The following is a description of a gene set: from publication Busslinger GA, Weusten BLA, Bogte A, Begthel H, Brosens LAA, Clevers H (PMID 33691112) species: Homo sapiens Human Gene Set: BUSSLINGER_DUODENAL_STEM_CELLS, and this is the list of marker genes: IRF2BP2, ELAPOR1, EIF3A, SERBP1, PAPOLA, TM4SF1, ATF3, CPS1, IPO7, TMEM230, IER2, RPL37A (ribosomal protein L37a), RPL27A, YWHAE, ITGA6, PIK3R1 (NCBI Gene Id 5295), CCL25, BTF3, CLDN3, ZFAS1, CEMIP2, ADRA2A, HNRNPDL, HSPD1, SPINK1, SOX4, SRSF6, ARF4, SELENOW (selenoprotein W), SOX9, CD46, MARCKSL1, RPL10, CEL, HMGB1, UBXN4, TRIM24, REG1A, AQP1, SNHG8, RPS23, TOMM7, IER3, CRLS1, CHCHD2, RPS15, RHOBTB3, RPS13, NCL, RPS18, BANF1, EEF1G, SNHG6, HNRNPC, EEF1A1, PKDCC, ARID5B, SNRPE, EIF3E, HSPA8, NSA2, APP, EML4, EEF2, ACTN1, HNRNPU, CNBP, COX7C, RPL8, GSTP1, CFTR, HNRNPA2B1, RCC2, LRIG1, TM9SF3, GOLM1, NOP56, NFIB, ERGIC3, RPL4, SCARNA9, ONECUT2, PDLIM1, RPL6, RPS7, PPIA, BMP4 (bone morphogenetic protein 4), TTC3, ATP5MC2, RPL15, GNL3, RPS29, CCND2, RPL27, NUCKS1, GAS5, BTG2, CD44, TXN, AHCY, RPS20, CES1, HNRNPK, ESRP1, RPL35, RPL41, HMGN1, RPS14, MECOM, SNHG29, RPL11, YWHAQ, BCL11A, CANX, RPL35A, RPS5, LRPPRC, FBL, CA9 (NCBI Gene Id 768), RPL39, RPL13A, ADD3, RPL31 (NCBI Gene Id 6160), RPL3 (ribosomal protein L3), RPS28, RPS2, EPCAM, RPL23, RNF43, PTGES3, CDCA7, XIST, RPL18, RACK1, MT1G, RPS15A, TOP2B, NONO, IMPDH2, VDR, ENC1, ZFP36L2, TXNIP, REPIN1, SYNCRIP, CD9, SPINT2 (NCBI Gene Id 10653), DSTN, ADH1C (NCBI Gene Id 126), NFIA, RPS16, HNRNPD, RPS27, SRP9, SH3D19, CLU (clusterin), CCND1, MLXIP, MLEC, U2AF1, HNRNPA1, EIF4B, SESN1, SH3BP4, RPL36, ASCL2, RPS27A, ZFP36L1, RPS4X, ZNF503, EIF2S3, FCGRT, RPS25, RPS11, RPL32, JUN, NR4A1, EIF3L, SNRPB, DMBT1, SH3BGRL2, GPX2 (NCBI Gene Id 2877), KRT8, RPL37, CDC42EP5, RPL30, EPHB2, HES1, C9orf152, MYB, DUT, HDAC2, SLC12A2, RPL34, FERMT1, FAM120A, SMOC2, PABPC1, TPD52, ATRX, RPL22L1, RCN1, RPL24, RPS3A, TKT, SNHG5, EIF4G2, AGR2, RPL22 (NCBI Gene Id 65281), HBEGF, CCT6A (chaperonin containing TCP1 subunit 6A), BCLAF1, SNX5, RPL5, SLC38A2, KHDRBS1, EGR1, RPS24, CERS6, RPS12, BEX3, RPL38, SMARCC1, HMGA1, NRARP, CDKN1B, EIF1AX, APEX1, DDAH1, ETS2 (ETS proto-oncogene 2, transcription factor), RPL7A, PTMA, REG3A, EDN1, CHDH, MATR3, CBX3, CDK6, LYZ, OLFM4 (NCBI Gene Id 10562), DACH1, RPL12, GPR160, TSPAN8 (NCBI Gene Id 7103, tetraspanin 8), TCF12, RPS9, YBX1, ZBTB38, GDF15, EMP2, RPS3, SFPQ, DDX21, RAD21, RPL26, XRCC5, RPS8, ANP32B, DSP, DARS1, NPM1, ATP5MC3, FOS, EIF5B, NCOA7, DSG2, HSP90AA1, SYNE2, HNRNPM, GCNT1, LAMB1, MCM7, SERP1, RPL14, MARCKS, RPL10A, HMGCS2, RPL7, NECTIN3, KLF5, YWHAZ, MYO10, SET, TSC22D1 (NCBI Gene Id 8848), RPS19, EIF4A2, FOSB, NOP58, RPL18A, TMEM123, RGMB, CLDN4, HSPE1, EIF3H, TPT1, RPLP1, HSP90AB1 (heat shock protein 90 alpha family class B member 1), RPS6, RPL13, TRIM28, DKC1, IVNS1ABP, PRKDC, EEF1B2, CRYZL2P, COQ8A, PPP1R1B, RPL9, OLA1, RAN, ACTG1